Given this list of marker genes MAPK8, IKBKB, MAP2K6, MAPK1 (NCBI Gene Id 5594), TLR9, CASP8, MAP3K7, MAPK3, CXCL11, TNF, NFKB1, IFNA2 (interferon alpha 2), IKBKG, AKT2, TOLLIP, IFNA1, IL1B, AKT1, CD80, IRAK4, IL12A, FADD (NCBI Gene Id 8772), IFNA13, MAP2K7, MAPK9, CHUK, MAP2K4, IFNA4, TAB1, CD14, IFNA16, TAB3, STAT1, TICAM1, CXCL9, TLR4, CXCL8, LBP, TAB2, NFKBIA, TLR5, FOS, TICAM2, TLR7, IFNA5, IFNA6, CD40, IRF7, TLR1, MAP3K8, MAP2K3, CD86, IFNB1, MAPK11, MAPK13 (mitogen-activated protein kinase 13), CXCL10, IL12B, IL6, CCL3, IKBKE, MAPK12, TIRAP, RELA, IFNA7, LY96, CCL5, IFNAR1 (NCBI Gene Id 3454), MAPK14, MAP2K1, TRAF3, JUN, TBK1, IRF3, TLR3, IFNA10, IFNA21, TLR2, CCL4, IRF5, MYD88, MAP2K2, IFNA8, TRAF6 (NCBI Gene Id 7189), NFKBIB, RIPK1, MAPK10, IRAK1, TLR6, AKT3, RAC1, IFNA17, TLR8, SPP1, IFNA14, IFNAR2, here is a description of the gene set: studied in species Homo sapiens Human Gene Set: WP_TOLLLIKE_RECEPTOR_SIGNALING Toll-like receptor signaling